The following is a description of a gene set: Apoptosis modulation by HSP70 Human Gene Set: WP_APOPTOSIS_MODULATION_BY_HSP70 species: Homo sapiens, and this is the list of marker genes: AIFM1, CYCS, MAP3K1, CASP8, APAF1, CASP7, MAPK10, TNFRSF1A, CASP3 (NCBI Gene Id 836), HSPA1A, NFKB1, CASP9, FADD, CASP6, CASP2, FAS, FASLG, RIPK1, BID